The following is a description of a gene set: Genes up-regulated in P493-6 cells (B lymphocyte, Burkitt's lymphoma model) by MYC and down-regulated by RNAi knockdown of TFRC. from publication O'Donnell KA, Yu D, Zeller KI, Kim JW, Racke F, Thomas-Tikhonenko A, Dang CV (PMID 16508012) Human Gene Set: ODONNELL_TARGETS_OF_MYC_AND_TFRC_DN species: Homo sapiens Overexpression of transferrin receptor 1 (TFRC1), a major mediator of iron uptake in mammalian cells, is a common feature of human malignancies. Therapeutic strategies designed to interfere with tumor iron metabolism have targeted TFRC1. The c-Myc oncogenic transcription factor stimulates proliferation and growth by activating thousands of target genes. Here we demonstrate that TFRC1 is a critical downstream target of c-Myc. Using in vitro and in vivo models of B-cell lymphoma, we show that TFRC1 expression is activated by c-Myc. Chromatin immunoprecipitation experiments reveal that c-Myc directly binds a conserved region of TFRC1. In light of these findings, we sought to determine whether TFRC1 is required for c-Myc-mediated cellular proliferation and cell size control. TFRC1 inhibition decreases cellular proliferation and results in G1 arrest without affecting cell size. Consistent with these findings, expression profiling reveals that TFRC1 depletion alters expression of genes that regulate the cell cycle. Furthermore, enforced TFRC1 expression confers a growth advantage to cells and significantly enhances the rate of c-Myc-mediated tumor formation in vivo. These findings provide a molecular basis for increased TFRC1 expression in human tumors, illuminate the role of TFRC1 in the c-Myc target gene network, and support strategies that target TFRC1 for cancer therapy., and this is the list of marker genes: HELLS, KBTBD8, CDK1, TMEM107, G3BP1, C4orf46, FUS, DBF4, DEPDC1, ARHGAP11A, TOP2A, SCD, BRCA2, FOXM1, TOX4, LRRC58, AURKB, CKS1B, RANBP1, FAM72C, CD151, DEPDC1B, RAD1, SNHG26, ERCC6L, AURKA, BIRC5, SPC25, POLE2, MND1, FAM181B, MYBL2, CCNA2 (cyclin A2), DNA2 (DNA replication helicase/nuclease 2), TFRC, BUB1B, LIN28B, NSD2, PLK4, CCNB1, CDC20, CDC6, ACACA (NCBI Gene Id 31), CENPF, HSPH1, CHAF1A